The following is a description of a gene set: This COVID-19 pathway has been created by a combination of computational inference from SARS-CoV-1 data (https://reactome.org/documentation/inferred-events) and manual curation, as described in the summation for the overall SARS-CoV-2 infection pathway.<br><br>The viral Spike protein of SARS-CoV-1 is subject to N-glycosylation and palmitoylation. The chaperone calnexin exclusively helps with protein folding. The end product is a homotrimer. In SARS-CoV-2 the Spike glycosylation patterns were extensively characterized, and consist of both N-glycans and O-glycans attached to about twenty amino acids. Although there is no reason for the host's glycosylation enzymes behaving differently than with other host or non-host proteins, direct involvement of host enzymes and chaperones with SARS-CoV-2 Spike glycosylation has not been shown. Indirect evidence from inhibition experiments is confounded by simultaneous inhibition of glycosylation of other proteins like the ACE2 receptor. part of: Translation of Structural Proteins Reactome Pathway: Maturation of spike protein_9694548 species: Homo sapiens, and this is the list of marker genes: EDEM2, ST3GAL3, MGAT2, TMEM258, MGAT5, ZDHHC20, MAGT1, ST3GAL1, STT3B, ST3GAL4, MGAT4A, ZDHHC5, DAD1, ZDHHC2, ST6GALNAC4, MAN1B1, CANX, MGAT4B, GOLGA7, ZDHHC9, RPN2, S, STT3A, MGAT4C, FUT8, DDOST, ST6GALNAC3, RPN1, OSTC, MOGS, PRKCSH, GANAB, TUSC3, OST4, ST3GAL2, ST6GAL1, ZDHHC3, ZDHHC11 (NCBI Gene Id 79844), MAN2A1, ZDHHC8, ST6GALNAC2 (NCBI Gene Id 6488), MGAT1